The following is a description of a gene set: species: Mus musculus The process in which the embryonic placenta is generated and organized. Mouse Gene Set: GOBP_EMBRYONIC_PLACENTA_MORPHOGENESIS, and this is the list of marker genes: Setd2, Igf2, Fgfr2, Cdkn1c, Spint2, Llgl2, Vcam1, Zfp36l1, Fzd5, Dnajb6, Ncoa1, Esx1, Itga4, Tmed2, St14, Bmp5, Gjb5, Grhl2, Ccn1, Il10, Spint1, Trim28 (NCBI Gene Id 98191), Bmp7, Wnt7b, Erf, Lef1, Ncoa3, Gcm1, Adm, Rspo3, Zfp568, Grb2, Socs3